Given this list of marker genes Ids, Ndst3, Gpc3 (NCBI Gene Id 14734), Sgsh, Sdc3, Hs3st2, Naglu, Slc35d2, Hs6st3, Ndst2 (N-deacetylase/N-sulfotransferase (heparan glucosaminyl) 2), Hs3st4, Ext1, Hs6st2, Hs6st1, Hpse2, Hs3st3b1, Sdc1, Gpc2, here is a description of the gene set: studied in species Mus musculus This event has been computationally inferred from an event that has been demonstrated in another species.<p>The inference is based on the homology mapping from PANTHER. Briefly, reactions for which all involved PhysicalEntities (in input, output and catalyst) have a mapped orthologue/paralogue (for complexes at least 75% of components must have a mapping) are inferred to the other species. Reactome Pathway: Heparan sulfate/heparin (HS-GAG) metabolism part of: Glycosaminoglycan metabolism electronically inferred by orthology from the curated human pathway